The following is a description of a gene set: Amino acids regulate mTORC1 studied in species Mus musculus Mouse Gene Set: REACTOME_AMINO_ACIDS_REGULATE_MTORC1, and this is the list of marker genes: Nprl2, Slc38a9, Rragb, Wdr59, Atp6v1c1, Nprl3, Bmt2, Atp6v1g2, Itfg2, Atp6v0e, Castor1, Atp6v1a, Sesn2, Atp6v0b, Atp6v1g1, Seh1l, Lamtor5, Flcn, Kics2, Depdc5, Lamtor3, Mtor, Mlst8 (MTOR associated protein, LST8 homolog (S. cerevisiae)), Atp6v1b1 (NCBI Gene Id 269766), Mios, Atp6v1f, Lamtor1, Atp6v0c, Sec13, Castor2, Rragc, Atp6v1e2, Rraga (Ras-related GTP binding A), Fnip1, Kptn, Sesn1, Atp6v1b2, Rptor, Atp6v1d, Atp6v1h, Atp6v1c2, Atp6v0d2, Sh3bp4, Fnip2, Lamtor2, Rragd, Lamtor4, Wdr24, Tcirg1, Rheb, Atp6v0e2, Szt2, Atp6v1e1, Atp6v0d1 (ATPase, H+ transporting, lysosomal V0 subunit D1), Atp6v1g3